The following is a description of a gene set: The protein catabolic pathway which targets endoplasmic reticulum (ER)-resident proteins for degradation by the cytoplasmic proteasome. It begins with recognition of the ER-resident protein, includes retrotranslocation (dislocation) of the protein from the ER to the cytosol, protein modifications necessary for correct substrate transfer (e.g. ubiquitination), transport of the protein to the proteasome, and ends with degradation of the protein by the cytoplasmic proteasome. studied in species Mus musculus Mouse Gene Set: GOBP_ERAD_PATHWAY, and this is the list of marker genes: Syvn1, Hsp90b1, Ubxn10, Marchf6, Sec61bl, Erlin1, Dnajc10, Xbp1, Svip, Ubxn2a, Ubqln1, Rnf121, Aqp11, Sel1l2, Canx, Brsk2, Calr3, Edem2, Cav1, Vcp, Rnft2, Erlin2, Calr4, Fbxo2, Eif2ak3, Ufd1, Sec61b, Trim13, Rhbdd1, Nrros, Hspa5, Tmem129, Wfs1, Ubxn4, Derl1, Fbxo44, Bag6, Nploc4, Rnf145, Atxn3, Man1a2, Nccrp1, Stt3b, Clgn, Dnajb12 (DnaJ heat shock protein family (Hsp40) member B12), Trim25, Edem1, Afg2b, Rnf103, Bcap31, Fbxo6, Ube2j2, Ubqln2, Usp14, Eif2a, Ube2g2, Foxred2, Tor1a, Tmem259, Selenos, Man1c1, Tmub1, Faf2, Derl3, Faf1, Rnf185, Usp25, Ubxn6, Tmem67, Tmub2, Rnf139, Ube4a, Ube2j1, Herpud1, Edem3 (ER degradation enhancer, mannosidase alpha-like 3), H13, Ubxn1, Calr, Ecpas, Get4, Rnf5, Ankzf1, Ccdc47, Ubxn8, Dnajb2, Amfr, Os9, Usp19 (ubiquitin specific peptidase 19), Ubac2, Jkamp, Man1b1, Fbxo27, Rcn3, Sdf2l1, Aup1, Ube4b, Derl2, Dnajb9, Yod1, Man1a, Rnft1, Umod, Sel1l, Usp13, Tmx1, Stub1, Ern1, Psmc6, Fbxo17, Erlec1, Sgta